Given this list of marker genes SOX6, SP4 (NCBI Gene Id 6671), WASF3, NBL1, GPR6, PITPNA, PPP3R1, RAB11FIP4, ENC1, ARID4A, NOL4, CHD1, ATG9A, NIBAN2, RFX7, EPHA7, PURB, ZNRF2, TNFRSF21 (TNF receptor superfamily member 21), FRK, DIP2B, SNX3, FOXP1, ANKRD13A, RALGPS1, UBE2D3, AP3M1, SH3BP5, OLR1, PTEN, ISM2, MIER3, DDX3X, RNF32, DYRK1A, SELENOT, KPNA6, PTPN4, JOSD1, SPG21, MCM7, ADCY1, TSPYL5, NRAS, MT1M, RCAN1, GFOD1, SULF2, CDV3, G3BP2, NF1, SUN2, EFCAB14, DPPA4, SPRY3, VCF1, RBAK, SRGAP1, KIAA1549, IQCH, CDC42BPB, ARID4B, NFIA, RORA, IQSEC3, TOPORS, ENO2, KCNMB4, SEMA6D, HSDL1, RAPGEF6, KCNK9, TMEM25, KIF13A, CLIP1, CGN, CDK12, BHMT, TBPL1, SCAMP2, CD5, RAD21, TMED6 (NCBI Gene Id 146456), GNS, TMEM143, RBM24, RC3H1, DCTN5, CDC37L1, KIF5C, GPR85, CASK, DCUN1D3, AKR1C3, DEPDC1B, MRAP2, STK33, TXLNA, TNRC6B, UBE2Q2, MACO1, CARD10, PDS5A, TMEM233, ANO3, ANKFY1, CRKL, KLHL21, HTATIP2, NR2C2, CLASP2, here is a description of the gene set: Genes predicted to be targets of miRBase v22 microRNA hsa-miR-3944-5p in miRDB v6.0 with MirTarget v4 prediction scores > 80 (high confidence targets). from publication Chen Y, Wang X (PMID 31504780) species: Homo sapiens Human Gene Set: MIR3944_5P